The following is a description of a gene set: This event has been computationally inferred from an event that has been demonstrated in another species.<p>The inference is based on the homology mapping from PANTHER. Briefly, reactions for which all involved PhysicalEntities (in input, output and catalyst) have a mapped orthologue/paralogue (for complexes at least 75% of components must have a mapping) are inferred to the other species. Reactome Pathway: Hyaluronan degradation species: Mus musculus electronically inferred by orthology from the curated human pathway part of: Hyaluronan metabolism, and this is the list of marker genes: Hyal5, Hexa, Hyal4 (NCBI Gene Id 77042), Slc9a1, Hyal2, Hmmr, Stab2 (stabilin 2), Hexb, Hyal1